Given this list of marker genes Poc1a, Cst5, Rarg, Atf2, Sox9, Nppc, Tgfbr2, Matn1 (matrilin 1, cartilage matrix protein), Col27a1, Ift80, here is a description of the gene set: species: Mus musculus Mouse Gene Set: GOBP_GROWTH_PLATE_CARTILAGE_CHONDROCYTE_DIFFERENTIATION The process in which a chondroblast acquires specialized structural and/or functional features of a chondrocyte that will contribute to the growth of a bone. A chondrocyte is a polymorphic cell that forms cartilage.